Given this list of marker genes PIK3CD, AKT1, AKT3, PIK3R1, PIK3R3, PIK3R2, ICOSLG, ICOS, AKT2, here is a description of the gene set: ICOSLG/ICOS-PI3K signaling pathway. Pathway ID: N01696. Pathway type: Reference. Pathway class: nt06530 PI3K signaling. species: Homo sapiens Pathway Definition from KEGG: ICOSLG -> ICOS -> PI3Kdelta -> PIP3 -> AKT Human Gene Set: KEGG_MEDICUS_REFERENCE_ICOSLG_ICOS_PI3K_SIGNALING_PATHWAY